Given this list of marker genes Ada, Cd44, Cd74, Bcl10 (B cell leukemia/lymphoma 10), Mif (NCBI Gene Id 17319), here is a description of the gene set: Mouse Gene Set: GOBP_REGULATION_OF_MATURE_B_CELL_APOPTOTIC_PROCESS species: Mus musculus Any process that modulates the frequency, rate, or extent of mature B cell apoptotic process.